The following is a description of a gene set: from publication Chen Y, Wang X (PMID 31504780) Human Gene Set: MIR3912_3P species: Homo sapiens Genes predicted to be targets of miRBase v22 microRNA hsa-miR-3912-3p in miRDB v6.0 with MirTarget v4 prediction scores > 80 (high confidence targets)., and this is the list of marker genes: SLC18A2, ZNF804A, DYNC1I2, PDSS2, SCYL2